Given this list of marker genes Uox, Xdh, Urad, Urah, Pnp, Pnp2, here is a description of the gene set: The chemical reactions and pathways resulting in the breakdown of inosine, hypoxanthine riboside, a nucleoside found free but not in combination in nucleic acids except in the anticodons of some tRNAs. Mouse Gene Set: GOBP_INOSINE_CATABOLIC_PROCESS species: Mus musculus